The following is a description of a gene set: Human Gene Set: GOBP_LOCOMOTION_INVOLVED_IN_LOCOMOTORY_BEHAVIOR species: Homo sapiens Self-propelled movement of a cell or organism from one location to another in a behavioral context; the aspect of locomotory behavior having to do with movement., and this is the list of marker genes: RCAN2, PPP3CB, GHSR, GPR37, RCAN1, FZD4, SLC25A46, GRIA1, CLN6, GNB3, ARRDC3, VPS35, DRD2